Given this list of marker genes RFXANK, STING1, HLA-DPB1, MPV17, PRTN3, PTPN22, TAP2 (NCBI Gene Id 92048), DOCK11, HLA-DPA1, CTLA4, EIF2AK4, here is a description of the gene set: The presence of autoantibodies in the serum that react against proteins predominantly expressed in cytoplasmic granules of neutrophils. species: Homo sapiens Cytoplasmic antineutrophil antibody positivity Human Gene Set: HP_CYTOPLASMIC_ANTINEUTROPHIL_ANTIBODY_POSITIVITY